The following is a description of a gene set: Mouse Gene Set: GOMF_HISTONE_H2A_UBIQUITIN_LIGASE_ACTIVITY Catalysis of the transfer of ubiquitin to a histone H2A substrate. studied in species Mus musculus, and this is the list of marker genes: Ubr2, Rnf2, Trim37, Rnf168, Pcgf3, Pcgf5